The following is a description of a gene set: studied in species Mus musculus Mouse Gene Set: GOMF_S_ADENOSYL_L_METHIONINE_BINDING Binding to S-adenosyl-L-methionine., and this is the list of marker genes: Prmt1, Ftsj1, Mocs1, Tsr3 (NCBI Gene Id 78765), Kmt5c, N6amt1, Kmt5b, Mettl14, Mettl3, Prmt8, Gnmt, Tpmt, Pcif1, Cbs, Mettl5, Setd6, Suv39h2, Bmt2, Tfb1m, Zcchc4, Mettl17